Given this list of marker genes ZBTB18, ICA1L, LINC01102, MIAT, POU3F2, NEUROD6, DOK5, RBFOX1, PLXNA4, ADCY1 (NCBI Gene Id 449484), LINC00342, CACNG8, SRCIN1, R3HDM1, CCBE1, CAMK2B, EPHB6, LHX2, ACTN2, SATB2, MAP6, MEIS2, SEZ6, PANTR1, SYT5, ENC1, MLLT3, CAMKV, GRIA2, DOCK9, DYNC1I1, ARPP21, PPP2R2B, NELL2, SCN2A, PRRT2, FBXW7, PCLO, SEMA3C, GOLGA8B, BHLHE22, PLXNA2, SYBU, SLA, CSRP2, CACNA2D1, NEUROD2, here is a description of the gene set: from publication Fan X, Dong J, Zhong S, Wei Y, Wu Q, Yan L, Yong J, Sun L, Wang X, Zhao Y, Wang W, Yan J, Wang X, Qiao J, Tang F (PMID 29867213) studied in species Homo sapiens Human Gene Set: FAN_EMBRYONIC_CTX_BIG_GROUPS_EXCITATORY_NEURON